Given this list of marker genes NTRK1 (NCBI Gene Id 7825), RHOG, AGRN, RAB3GAP1, MMUT, SEMA4D, TIAM1, RGS16, ZC3H15, USP6NL, EVI5L (NCBI Gene Id 115704), RSU1, ARAP1, ASAP3, CORO1C, RAP1GAP, RGP1, RGS6, THY1, LARS1, SNX18, EZH2, RAPGEF6, USP17L2, RALGAPB, MTSS2, ARHGAP11B, TBC1D2, ARHGAP42, RALGAPA1, SIPA1L1, RAPGEF1, RASGRP1, RALGAPA2, SYDE2 (NCBI Gene Id 84144), TBC1D20, SYDE1, NET1, SNX9, ODAM, ARHGEF7, EPHA2, PRTN3, LIMS1, ARHGAP11A, GNB5 (NCBI Gene Id 82962), RASGRP2, SNX13, RANGAP1, S100A10, ALS2, BCAR3, DOCK10, BCR, RAPGEF3, NF1, DOCK9, SGSM2, RGS10, RAPGEF2, PLXNB1, ADCYAP1, RTN4R, TBC1D30, RAP1A, RGS8, TGM2, DOCK11, ARHGEF16, DOCK8, SRGAP2, CCDC125, RAB11FIP2, SGSM3, ITGB1, RIC1, RACK1, RGS7, RALBP1, TBC1D7, ITGA6 (NCBI Gene Id 3655), F2RL1, PIP5K1A, SCRIB, APC2, ABR, SH3BP1, EVI5, NDEL1, TSC1, DVL3, ECT2, RGS1, here is a description of the gene set: Human Gene Set: GOBP_POSITIVE_REGULATION_OF_GTPASE_ACTIVITY Any process that activates or increases the activity of a GTPase. species: Homo sapiens